The following is a description of a gene set: from publication Grützmann R, Boriss H, Ammerpohl O, Lüttges J, Kalthoff H, Schackert HK, Klöppel G, Saeger HD, Pilarsky C (PMID 15897887) Human Gene Set: GRUETZMANN_PANCREATIC_CANCER_UP Pancreatic ductal adenocarcinoma is the eighth most common cancer with the lowest overall 5-year relative survival rate of any tumor type today. Expression profiling using microarrays has been widely used to identify genes associated with pancreatic cancer development. To extract maximum value from the available gene expression data, we applied a meta-analysis to search for commonly differentially expressed genes in pancreatic ductal adenocarcinoma. We obtained data sets from four different gene expression studies on pancreatic cancer. We selected a consensus set of genes measured in all four studies and applied a meta-analysis approach to evaluate the combined data. Of the genes identified as differentially expressed, several were validated using RT-PCR and immunohistochemistry. Additionally, we used a class discovery algorithm to identify a gene expression signature. Our meta-analysis revealed that the pancreatic cancer gene expression data sets shared a significant number of up- and downregulated genes, independent of the technology used. This interstudy crossvalidation approach generated a set of genes that were consistently and significantly dysregulated in pancreatic cancer. Of these, 364 (64.1%) were upregulated and 204 (35.9%) were downregulated in pancreatic cancer. Only 127 (22%) were described in the published individual analyses. Functional annotation of the genes revealed that genes presumably associated with the cell adhesion-mediated drug resistance pathway are frequently overexpressed in pancreatic cancer. Meta-analysis is an important tool for the identification and validation of differentially expressed genes. These could represent good candidates for novel diagnostic and therapeutic approaches to pancreatic cancer. species: Homo sapiens Genes up-regulated in pancreatic ductal adenocarcinoma (PDAC) identified in a meta analysis across four independent studies., and this is the list of marker genes: CTPS1, PDIA2, RAB5B, S100A10, PRR13, ANXA5, PSMD14, SERPINA1, CENPF, CDH11, FOXF1, DGKD, MCM6, MPP3, FYN, C2, PUF60, GDI1, IL1RN, SEM1, PLAUR, AKAP1, PLEC, ADSS2 (NCBI Gene Id 159), ARL4A, MYL9, SLC1A3, COPS8, MMD, LTBP1, MRPS12, G3BP1, HCCS, SPARC, APLP2, GM2A, RALB, ARHGEF2, RIN1, STMN1, YWHAZ, GRB2, PSG11 (pregnancy specific beta-1-glycoprotein 11), LGMN, KYNU, EIF4G3, LCN2, CSNK1A1, TUBA1A, HMGB2, BST1, ITGB5, TIMP3, TUSC3 (tumor suppressor candidate 3), ACOT7, CASP1, CYTH1, GPX4, MKI67, IFI44L, ETFB, TOP1, PSMA5, DPYSL3, USP14, PCOLCE, POLB, CD55 (NCBI Gene Id 1604), GET3, CSTB, BPTF, CRABP2, TNFAIP3, GK, RGS16, ITGA3, FN1, DPYD, IQGAP1, PPP2R1A, DGKA, PDE1A, CDC25B, TFF1, LAPTM5, SMAD3, IFITM2, CHMP1A, MMP11, CKS2, FCGR3A, GPC1, TAP1, BIRC3, FLAD1, MMP9, DNMT1, PNP, H2BC21, PIK3R4, KRT13, ADAM10 (NCBI Gene Id 102), CASP4, FLOT2, EMP3, PLCG2, HPGD, FBLN2, UBE2C, PMP22, DLAT (NCBI Gene Id 1737), COL5A2, ATP6AP1, GUSBP11, SRGN, PPIG, PGK1, WNT2, CDK7, VCAN, CCNG2, CD9, TM9SF4, PARP4, LUM, CALD1, MYLK, CD86, PRKACB, PKM, SERPINE1, LAD1, ZMYND8, WNT5A, LAMP2, SUMO1, SLC2A1, DYNLT3, LCP1, CD1C, SFN, PIP4K2B, AMPD3, PSMB3, HMGN4 (NCBI Gene Id 10473), CNN1, PTGS2, EVPL, MELK, NMT1, FAP, SLBP, ITGB4, CXCR4, RAB2A, ANXA1, MMP2, GEM, AFAP1 (NCBI Gene Id 60312), XRCC4, TFF3, DUSP5, IFI30, ABCG1, SPINT2 (serine peptidase inhibitor, Kunitz type 2), LCP2, ARHGDIA, CSE1L, PTGS1, KDSR, SLPI, CLOCK, TXNRD1, RHOA, CD47, TIAL1, SELENOW, SIDT2, FOXK2, ECM1, PYGL, SEPTIN8, CAV2, PHB1, PSMC6, TNFAIP6, MGP, VDAC1, MYH9, CRIP2, IL4R, SUSD6, GRN, ALDOC, TSN, DLST, LDHA, SRI, CTSC, SDC1, TANK, NBL1, CAV1, SNRPB2, CETN2, ATP1B3, TMSB10, ENO1, PYGB, SORL1, DUSP6, CFLAR, ARL6IP1, UGCG, APOC1, CLIC1, IRS1, TBCB, P4HA1, TSC22D1, CSK (C-terminal Src kinase), KLF5, DHX9, NDUFB7, KCNK1 (potassium two pore domain channel subfamily K member 1), NNMT, PLN, PAK2, OAS1, GSN-AS1, RFC4, CBX3, SHC1, AKAP12, NR1D1, CELF2, WNK1, ARHGAP1, CD53, STAT1, DNAJA1, MYL6B, PCLAF, IGFBP5, R3HDM1, MX2, MSMO1, KLF4, LMO4, H2AC18, HNRNPU, GPI, PDGFRB, LOXL2, RCN1, SEC23A, XPO1, ATF3, GADD45A, DOCK2, LAMA3, PPP3CA, FABP5, FYB1, ALOX5, PTPRC, TSPO, MBOAT7, GOLIM4, NDRG1, PLOD2, ACVR1, CBR1, PTPN12, EIF2AK2, RHOG, ISG20, ITGB1BP1, MYL12A, SNRPA, INPP1, WASHC5, ENTPD1, ADAM9, DYRK2, PLAT, CCNA2, SERPINH1, GPX1, PSME3, POSTN (periostin), SCNN1A, CYFIP1, BZW1, ELF4, RALBP1, RAP1GAP, YWHAH, NID1, MAP4, HBA2, TOP2A, RAB31, ITGB2, PFN1, S100P, GBP2, GABRE, CKS1B, EPS8, PTPN9, NDUFA9, ITGA2, MSN, DHX8, PRKDC, COL1A1 (collagen type I alpha 1 chain), STOM, FBN1, MPHOSPH6, SPTA1, PPP1R8, SULT1C2, PSMA3, GLUD1, PRDX1, AREG, TRADD, GGT5, MYH10, PRNP, ITPR3, SOD1, NCBP2, TUBB, MFSD10, ACYP1, MCM3, TFCP2, TRIM29, PXDN, S100A11, ANXA8, HLA-DRA (major histocompatibility complex, class II, DR alpha), NSDHL, EMP2, PLAU, CTSL, BST2, EXOSC7, LAMA4, THBS2, CBFB, NREP, NUP93, TRIP10, GNPDA1, GBP1, CTSK